The following is a description of a gene set: Mouse Organogenesis Cell Atlas (MOCA) DE_gene_main_cluster.csv, fold.change>=1.5, qval<0.05, pval<0.05 Mouse Gene Set: DESCARTES_ORGANOGENESIS_NOTOCHORD_CELLS studied in species Mus musculus from publication Cao J, Spielmann M, Qiu X, Huang X, Ibrahim DM, Hill AJ, Zhang F, Mundlos S, Christiansen L, Steemers FJ, Trapnell C, Shendure J (PMID 30787437), and this is the list of marker genes: Dchs2, Sp5, P4ha3, Efnb3, Gdpd2, Eva1c (NCBI Gene Id 73543), Iqcj, Cptp, Gm38839, Foxa2, Nectin3, Jhy, Nudt16l1, Slit1, Iqschfp, Corin, Gm12724, Adgra1, Foxa1, Tacr1, Ttc6, Dipk2a, Lrtm1 (leucine-rich repeats and transmembrane domains 1), Ccdc3, 5530401A14Rik, Spon1, Adcyap1r1, Gm36640, Clxn, 9330111N05Rik (NCBI Gene Id 319983), Kbtbd11, 9030622O22Rik, Gcnt2, Schip1, Ntn1, Metrnl, Adgrv1, Ablim2, Adamts16, Gm20139, Gm13832, Nrbp2 (NCBI Gene Id 223649), Ankfn1, Halr1, Smpdl3a, Galr1, Sim2, Shisa9, Hey1, Crhbp, Ephb2, Klhdc8a, Dbx1, 5830408C22Rik, Fgf14 (fibroblast growth factor 14), Apela, Gm973, Psd3, E130308A19Rik, Ppm1l, Gm29346, Gm15578, Syt17, Gm16246, Lgi3, Baiap3, Tox2, Gm12296, 4930518C09Rik, Shh, A930005G22Rik, Erich3, 9530036O11Rik, Pdyn, Ralgps2, Stxbp6, Rp1